The following is a description of a gene set: studied in species Mus musculus Mouse Gene Set: GOMF_L_ORNITHINE_TRANSMEMBRANE_TRANSPORTER_ACTIVITY Enables the transfer of L-ornithine from one side of a membrane to the other. L-ornithine is 2,5-diaminopentanoic acid., and this is the list of marker genes: Slc25a15, Slc25a2, Slc7a3, Slc7a2, Slc7a1